The following is a description of a gene set: Mouse Gene Set: HEVNER_TELENCEPHALON_MENINGEAL_CELLS from publication Bedogni F, Hevner RF (PMID 34321999) species: Mus musculus Genes selectively expressed by meningeal cells in embryonic day 14.5 mouse telencephalon., and this is the list of marker genes: Rdh10, Adamts12, Cthrc1, Col6a1, Serpinf1, Lama2, Slc6a13, Tex15, Slc38a4, Ptgds, Foxc1, Col13a1, Lama1, Dab2, Colec12, Fxyd5, Svil, Pf4, Fbln1, Tbx18, Col6a3, Bmp7, Col26a1, S100a11, Col1a2, Lgals1, Dcn, Ranbp3l, Col5a1, Itih5, Bicc1, Fbn2, Col23a1, S100a10, Arpc1b, S100a6, Aldh1a2, Cyp1b1, Foxd1, Emilin1, Cldn11, Mmp2, Emp3, Selenop, Islr, Postn, Alx3, Agtr2, Lum (NCBI Gene Id 17022)